Given this list of marker genes Pramel51 (PRAME like 51), Ubqln3, Oog4, Ttc3, Pramel38, Ube3d, Trim28, Rnf149, Csnk2b (NCBI Gene Id 13001), Rnf26rt, Wdr77, Sufu, Cul1, Fbxl2, Klhl5 (kelch-like 5), Csnk1a1 (casein kinase 1, alpha 1), Hecw2, Trp53inp2, Psmd6, Klhl35, Rnf215, Ascc3, Nop53, Fbxw7, Foxf2, Rmnd5a (NCBI Gene Id 79046), Pramel26, Atxn3, Pmp22, Chmp1b2, Ubb, Prmt6, Cul4a, Gabarap, Ube2g2, Hamp (NCBI Gene Id 84506), Tnfaip1, Rc3h1, Kcmf1, Herpud1, Det1, Pramel43, Psmb7, Pramel21, Uba1y, Psmd10, Kctd6, Psmb10, Ufl1 (UFM1 specific ligase 1), Pbk, Ube2j2, Dcaf11, Anapc11, Fbxo44, Ube4b, Ptpn23, Klhl4, Pramel48, Uchl4, Rps7, Bfar, Psma4, Ubxn2a, Tnfaip3, Pramel18, Mapk8, Socs4, Trib3, Gba1 (NCBI Gene Id 14466), Vps4a, Ark2n, Ube2z, Tut4, Wac, Chmp5, Bbs7, Sumo1, Axin1, Rnf7 (NCBI Gene Id 19823), Sh3rf3, Peli1, Hecw1, Ubr1, Fbxl3, Ambra1, Caml, Dtl, Faf2, Klhl12, Bcap31, Herc2, Desi1, Taf9, Xpo1, Rnf213, Rnf111, Agbl4, Dcaf12, Spop, Psmd14, Ccin, Cdk5rap3, Dda1, Egf, Csnk2a2, E330034G19Rik, Rybp, Arrdc4, Snhg15, Trim72, Anapc10, Ubc, Armc8, Gsk3b, Hspbp1 (HSPA (heat shock 70kDa) binding protein, cytoplasmic cochaperone 1), Fbxl14, Sh3rf1, Fbxw8, Pramel36, Zer1, Appbp2, Spsb2, Tdpoz8, Fbxo48, Siah2, Zfand2b, Styx, Pramel12, Rnf7l, Zfp598, Pramel45, Pramel5, Tsg101, Psma3, Amfr, Dvl1, Epg5, Trim71, Sirt1, Pramel47, Psmd3, Pramel55, Arih1, Rnf144a, Rnf8, Ubqln5, Ube2d2b, Cbfa2t3, Trip4 (thyroid hormone receptor interactor 4), Rnf43, Pramel6, Cdkn2a, Klhdc10, Trim13, Tdpoz5, Smarcc1, Kctd13 (potassium channel tetramerisation domain containing 13), Eloc, Anks1, Pml, Rnf139, Rnf148, Afg2b, Ccdc22, Pramel35, Gid8, Klhl8, Disc1, Klhl29, Psmc3, Rnf122, Klhdc1, Gsk3a, Rbx1-ps, Klhl11, Pramel42, Anapc5, Rbck1, Cdc34b, Ercc8, Cul2, Keap1, Fbxw11, Fbxo7, Ccnf, Os9, Psen2, Psmb6, Klhl24, Fbxw5, Fbxl20, Apc2, Tdpoz9, Il33, Rnf25, Hfe, Usp7, Psmc6, Bag6, Rnf144b, Gan, Psma7, Klhl40, Oog2, Pramel40, Klhdc2, Rnf150, Asb11, Cd2ap, Znrf3, Psma2, Arel1, Klhl42, Wdr26, Pramel60 (PRAME like 60), Ube2g1, Rlim, Klhl38, Rnf185, Liat1, Uhrf1, Siah1a, Vps37b, Usp26, Kbtbd3, Lonp1, Nhlrc3, Ube2srt, Fbxo11 (NCBI Gene Id 98072), Rnf128, Usp38, Tbl1xr1, Ankrd9, Pramel46, Ube2h, Mylip, Rybp-ps, Anapc2, Ctnnb1, Rffl, Tdpoz4, Uba52, Plk3, Cdc26, Psmb5, Lrrk2, Trim45, Rnf34 (NCBI Gene Id 97276), Dis3l2, Wnt1, Skp2, Styx-ps, Klhl17 (NCBI Gene Id 231003), Cop1, Trim3, Ntan1, Ubxn11, Edem1, Otud7a, Mta1, Dtx4, Skp1, Agap3, Chmp1b, Chmp7, Dmac2, Socs5, Fbxo2 (NCBI Gene Id 277695), Tlk2, Kbtbd7, Psma1, Itch, Rnf40, Rnf216, Rpl11, Pramel33, Pramel31, Rnf11, Csnk1e, Ube2b, Siah3, Psma6, L3mbtl3, Fbxl6, Map1a, Rnf19b, Apc, Pramel19, Klhl25, Fbxo31, Pramel41, Huwe1, Kctd17, Tut7, Kbtbd8, Psen1, Fbxo4, Rpl5, Rpl23, Fbxo38, Ube4a, Nedd8, Hsp90ab1, Rnf5, Clock, Rnf126, Fbxl12, Zswim8, Ccar2, Ubr5, Usp22, Rps27a, Psmd13, Zmpste24, Pja2, Klhl10, Sgta, Ube2l6, Cul9, Socs7, Hdac6, Oog1, Ubap1l, Fem1al, Klhl7, Pramel11, Vps25, Get4, Tdpoz3, Psma5, Vps37c, Qrich2, Psmc1, Gid4, Pramel13, Klhl18, Trpc4ap (NCBI Gene Id 56407), Trim63, Ppp2r5c, Gm13040, Rnf14, Klhl20, Ivns1abp, Pramel28 (PRAME like 28), Fbxo22, Psmd4, Kbtbd2, Anapc15-ps, Traf7 (TNF receptor-associated factor 7), Birc2, Trip12, Fem1b, Rnf146 (NCBI Gene Id 68031), Rnf10, Ube2v2, Uchl5, Fhit, Wwp2 (NCBI Gene Id 66894), Fbxl13, Sumo2, Fbxo8, Syvn1, Fbxo27, Ube3b, Fbxl18, Bmal1, Trim2, Cul7, Klhl22 (kelch-like 22), Psmc4, Ubqln4, Sirt2, Wnt10b, Prickle1, Ube2u, Klhl21, Egfr (epidermal growth factor receptor), Xbp1, Ddrgk1, Spopfm3, Kbtbd12, Zfand2a, Vps28, Klhl41, Bap1 (NCBI Gene Id 69465), Marchf6, Herc3, Phf20l1 (NCBI Gene Id 239510), Fbxl7, Nhlrc1, Ube2dnl1, Pramel30, N4bp1, Rnf123, Rnf26, Psmd8, Uchl3, Stam, Lnx1, Shh, Ube2c, Rnf167, Crbn, Ube2d1, Tbx21, Zfp418, Pramex1, Rnf166, Lrrc75a, Pramel25, Paqr3, Klhl3, Ube2d2a, Cdc20, Ddit3, Arrdc1, Zranb1, Sharpin, Gipc1, Klhl28, Cacul1 (CDK2 associated, cullin domain 1, NCBI Gene Id 78832), Rnf145, Rbx1, Nemf, Snf8, Psmd11, Arrb2 (arrestin, beta 2), Chmp2b, Zyg11b, Pabir1, Pramel23, Socs2, Trim9, Vps4b (vacuolar protein sorting 4B), Trim31, Ipp, Psmb2, Rnf217, Kctd5 (potassium channel tetramerisation domain containing 5), Rnf130, Pramel27, Pramel29, Hspa1b, Cdc20b, Epm2a, Svip, Cdc34, Ndfip1, Plk2, Pcyox1, Csnk1d, Mtm1, Mib1, Herc6, Amn1, Ttc36, Nedd4, Ptk2, Fbxl15, Rnf133, Fbxl22, Dtx3l, Pramel14, Psmd1, Ube3a, Clu, Gna12, Pcbp2, Rnf6, Znrf4, Ubqlnl, Znrf1, Spopfm2, Fbxo3, Rnf187, Chmp6, Psmd7, Psmb9, Senp1, Ubqln2, Psmb3, Kctd2, Pramel22, Ogt, Lats1, Uba6, Rad23b, Klhl2, Fbxl5, Tdpoz1, Ate1, Park7, Pten, Pdcl3 (phosducin-like 3), Hectd1, Chmp4b, Asb1, Pramel37, Rack1, Psmc2, Spsb3, Chmp2a, Fbxl9, Ppp1r11, Dab2, Otud5, Rnf170, Akirin2, Traf4 (NCBI Gene Id 320278), Anapc1, Usp14, Ubr2, Nccrp1, Usp5, Ltn1, Fbxo45 (F-box protein 45), Pcyox1l, Klhl30, Anapc13, Derl1, Nub1, Arih2, Nploc4 (NCBI Gene Id 276977), Trim32, Trim39, Vps37a, Ankib1, Pcnp, Rad23a, Psmb11, Rnf186, Edem3, Pramel1, Trib1, Hipk2, Ubqln1, Fem1a, Fbxl19, Rnf19a, Cops3, Asb2, Rnf115 (NCBI Gene Id 99831), Klhl1, Rmnd5b, Ube2k, Psmb8, Hectd3 (HECT domain E3 ubiquitin protein ligase 3), Chmp1a, Wdr81, Gclc, Uchl1, Chmp3, Ube2s, Ecrg4, Rnf4, Ube3c, Trim25, Anapc16, Sh3rf2, Klhl6, Cblc, Mtor, Znrf2, Nsfl1c, Ddb1, Cdc16, Dcst1, Fbxo17, Trim38, Cnot4, Rbbp6, Nedd4l (NCBI Gene Id 83814), Ube2r2, Agtpbp1, Psma8, Kat5, Fbxl16, Ubap1, Fem1c, Rnf168, Spsb1, Klhdc3, Commd1, Sh3bgrl, Rnf125, Klhl23, Rpgr, Ascc2, Wwp1, Vcp, Usp44, Chfr (NCBI Gene Id 231600), Vps36, Rnf20, Sirt6, Uba7, Nfe2l2, Fbxl4, Smurf1, Ube2d3, Klhl15, Trim58, Ubd, Rhobtb3, Aurka, Plaa, Trim26, Pabpn1l, Tollip, Pramel16, Dnajb2, Axin2, Tdpoz2, Oog3, Ubl4a, Ndfip2, Pramel53, Cul3, Uba1, Ubr4, Dcaf1 (DDB1 and CUL4 associated factor 1), Naglu, Rnf114, Atg7, Cul5, Kctd10, Kbtbd6 (NCBI Gene Id 432879), Wwtr1, Chmp4c, Mkrn2 (NCBI Gene Id 97310), Smurf2, Ubxn7, Ptk2b, Ube2w (ubiquitin-conjugating enzyme E2W (putative)), Trib2, Clec16a, Stub1 (STIP1 homology and U-Box containing protein 1), Btrc, Bag5, Siah1b, Hspa1a, Tgfb1i1, Pramel24, Rnf13, Laptm5, Araf, Herc4, Spsb4, Tmem168, Otud7b, Tent4a, Vhl, Pramel17 (NCBI Gene Id 545662), Asb9, Ube2a, Bag2, Nkd2, Ubl7, Tmem129, Psmc5, Topors (NCBI Gene Id 230074), Sumo3, Akt1, Kctd21, Ufd1, Fbxo9, Isg15, Trim67, Rchy1, Kif14, Psmd2, Tent4b (terminal nucleotidyltransferase 4B), Trf, Rc3h2, Anapc15, Ube2n, Pramel15, Fbxl17, Ubxn2b, Fbxo39, Usp28, Fbxo10 (NCBI Gene Id 269529), Glmn, Hace1, Anapc4, Anapc7, Maea, Mdm2, Arrb1 (arrestin, beta 1), Prkn, Fau, Cdc27, Mapk9, Pramel44, Fbxo6, Plk1, Ube2dnl2, Fzr1, Psmf1, Cdc23, Fbxw4, Ubxn1, Cbl, Pramel20, Ube2l3, Usp25, Eif3h, Pramel32, Ubr3, Dcaf13, Vps37d, Usp9x, Map3k1, Tbl1x, Pias1, Psmb4, Spopl, Cul4b, Ppp2cb, Pramel7, Rnf180, here is a description of the gene set: Mouse Gene Set: GOBP_MODIFICATION_DEPENDENT_MACROMOLECULE_CATABOLIC_PROCESS The chemical reactions and pathways resulting in the breakdown of a macromolecule, initiated by covalent modification of the target molecule. studied in species Mus musculus